The following is a description of a gene set: Genes positively differentially expressed in cell type: CD4+ T cell upon treatment with cytokine: IFN-α1 in mouse lymph nodes in vivo. studied in species Mus musculus Mouse Gene Set: CUI_T_CELL_CD4_IFNA1_RESPONSE_UP from publication Cui A, Huang T, Li S, Ma A, Pérez JL, Sander C, Keskin DB, Wu CJ, Fraenkel E, Hacohen N (PMID 38057668) Cytokines mediate cell-cell communication in the immune system and represent important therapeutic targets. A myriad of studies have highlighted their central role in immune function, yet we lack a global view of the cellular responses of each immune cell type to each cytokine. To address this gap, the authors created the Immune Dictionary, a compendium of single-cell transcriptomic profiles of more than 17 immune cell types in response to each of 86 cytokines (>1,400 cytokine-cell type combinations) in mouse lymph nodes in vivo. A cytokine-centric view of the dictionary revealed that most cytokines induce highly cell-type-specific responses. For example, the inflammatory cytokine interleukin-1β induces distinct gene programmes in almost every cell type. A cell-type-centric view of the dictionary identified more than 66 cytokine-driven cellular polarization states across immune cell types, including previously uncharacterized states such as an interleukin-18-induced polyfunctional natural killer cell state., and this is the list of marker genes: Ttc39b, Nsd3, Gpr65, Keap1, Phip, Vps37b, Ilrun, Tbrg1, Man2a1, Zup1 (NCBI Gene Id 72580), Isg15, Gbp4, Psma5, Svbp, Sla, Inpp1, Lgals9 (NCBI Gene Id 16859), Fam241a (NCBI Gene Id 97083), Arf4, Slco3a1, B2m, Mndal, Samd9l, Tspo, Phf11c, H2-T22, Usf1, Itm2b, Xaf1, Mycbp2, Tapbp (NCBI Gene Id 28066), Gbp9, Il2rg, Stat3, Ascc3, Plgrkt, Art2b, Tor1aip2, Etnk1, Parp12, Ifi47, Pnp, Tuba1b, Cnp, Ly6a, Bbx, Ifit3b, Tmem192, Dbnl (NCBI Gene Id 13169), Itpr1, Stat1, Cd47, Azi2, Cd274, Mvb12a, Pttg1, Ezr, H2-K1, Nmi, Oas3, Setdb2, Gbp8, Asb13, Xrn1, Tor1aip1, H2-Q7, Hspa5, Jaml, Psme2b, H2-M3, Mitd1 (MIT, microtubule interacting and transport, domain containing 1), Trim34a, Arl6ip1, Nes, Taldo1, Plac8, Mrpl30, Lgals3bp (lectin, galactoside-binding, soluble, 3 binding protein), Irgm2, Pim1, St6galnac4, Ifi204, Atm, Ltb, Ifi213, Irgm1, Dhx58, Nub1, Igtp, Pdia3, Casp8, Sell, Psma2, Ifit2, Msn, Tapbpl, Gbp3, Ly6e, Ube2l6, Gbp6, Vcpip1, Akr1b1, H2-T24, Insl6, Parp14, Daxx, Max, Idnk, Laptm4a, Ifi44, 9930111J21Rik2, H2-D1, Irf2, Mov10, Sp140, Tmsb10, Treml2, H3f3b, Rigi, Nlrc5, Psma7, Rsad2, Sh3glb1, Aldoa, Pdcd10, Capza2, Rnf114, Zc3hav1, Nampt, Vars1, BC051226, Rbl1, Slfn5, Armc3 (NCBI Gene Id 70882), Chmp5, Trim56, Ms4a4c, Cd2, Nsg2, Rfc3, Gbp2, Lgals8, Rbm43, Phgdh, Slfn8, Psmb10, Slc25a22, Tor3a, Cnot6l, Hsbp1, Oas1a, Rnf213, Ifit3, Cd69, Epsti1, Slfn2, Myd88, Parp9, Pml, H2-Q6, Phf11a, Parp11, Rgs1 (NCBI Gene Id 50778), Ddx24, Sub1, Med28, Grina, Tap1, Vps54, Tbl1x, Sp110, Aida, Reep3, Trim30d, Iigp1, Ly6c1, Tap2, Dtx3l, Ppp6r1, Ly6c2, Irf9, Calhm6, Ogfr, Hk1 (NCBI Gene Id 15275), Ankfy1, Zbp1, Tnfsf8, Pgd, Psma4, Selenow, Gbp7, Samhd1, Ifi203, Clic4, Stat2, Psmb8, Ms4a6b, Atg13, Tcstv4, Gzma, Ifnar1, Oasl1, Otud5, Ifi214, Shisa5, Ifi206, Myl12b, Ppa1 (NCBI Gene Id 67895), Ifi27l2a, Ubb, Sidt1, Ncoa7, Ccnd2, Sp100, Gadd45g, Mx1, Clec2d, Irf1, Smchd1, Ifit1, Ctss, Tut4, Bst2, Cd53, Trim21, B4galt5, Ifi35, Uba7, Psme1, H2-T23, Rabepk, Tmem184b, Oas2, Msh3 (NCBI Gene Id 17686), Fchsd2, Stk24, Atp10a, Psme2, Pstpip1, Atp8b4, Socs1, Cxcl10, Plaat3, Evl, Cd86, Ubald2, Camk2d, Tcof1, Rtp4, Trim30a, Trim14, Herc3, Arhgap25, Nup210, Tnfsf10, Tmbim6, Ndrg3, Isg20, Prrc2c, Lpp, Eif5a, Erap1, Gtpbp2, Ifih1 (NCBI Gene Id 71586), Ddx60, Ifit1bl1, Atp8a1, Trim25, N4bp1, Fnbp4, Morc3, Adar, Eif2ak2, Dynll2, Cmc1, Phyh, Trim12c, Phc2, Znfx1, Trafd1, Ubc, Trim12a, Arfgef1, Snx2, Chmp4b, Fam111a, Usp18, Oasl2, Trim30c, Tasor2, Hmox2, Zcchc2 (NCBI Gene Id 98679), Parp10, Hsh2d, Ms4a4b, Mgat1, Mvp, Rbck1, Cep57l1, Tgtp1, Ifi209, Xrn2, Nt5c3, Ifi208 (NCBI Gene Id 100033459), Ifitm3, Socs3, Tbc1d1, H2-Q4, Phf11b, Usp25, Cntrl, Gramd2b, Slfn1, Dpp4, Irf7, Helz2, Csrp1, Apobec3, Pcgf5, Notch1, Tgtp2, Sh3gl1, Gbp5, Cmpk2, Psmb9, Larp1, Naa20, Acadl, Sdc3, Herc6